Given this list of marker genes AFMID, NADSYN1, NMNAT1, TDO2 (NCBI Gene Id 6999), IDO1, KYNU, NAPRT, AADAT, KMO, QPRT, NMRK2, NAMPT, NMNAT2 (NCBI Gene Id 23057), NMNAT3, NMRK1, HAAO, here is a description of the gene set: studied in species Homo sapiens Tryptophan catabolism leading to NAD+ production Human Gene Set: WP_TRYPTOPHAN_CATABOLISM_LEADING_TO_NAD_PRODUCTION